The following is a description of a gene set: from publication Chen Y, Wang X (PMID 31504780) species: Mus musculus Mouse Gene Set: MIR_6977_5P Genes predicted to be targets of miRBase v22 microRNA mmu_miR_6977_5p in miRDB v6.0 with MirTarget v4 prediction scores > 80 (high confidence targets)., and this is the list of marker genes: Vps13d, Ly6e, Nr2e1, Zeb2, Caprin2